Given this list of marker genes Mapk8, Disc1, Actb, Dlg1, Prc1, Kifbp, Stau2, Tor1a, Kif5a, Klc2, Dcdc2a, Mapk8ip2, Ttbk2, Ktn1, Map7d2, Cimap3, Sptbn5, Kif18b, Kpnb1, Plekhm2, Rab29, Dcp1a, Fam83d, Shtn1, Lrp8, Ap1ar, Klc4, Crocc, Mapk8ip1, Kcna2 (potassium voltage-gated channel, shaker-related subfamily, member 2), Dlg4, Kifap3, Trak2, Snca, Ift88, Nek6, Clstn1, Daxx, Tor1b (NCBI Gene Id 70214), Arhgef10, Spag9, Nup62, Kif3a, Atcay, Ap1g1, Magi2, Jakmip1, Klc3, Klc1, Kcnc1, Kif3c, Mapk8ip3, here is a description of the gene set: Mouse Gene Set: GOMF_KINESIN_BINDING species: Mus musculus Interacting selectively and non-covalently and stoichiometrically with kinesin, a member of a superfamily of microtubule-based motor proteins that perform force-generating tasks such as organelle transport and chromosome segregation.